Given this list of marker genes CALHM6, FCN1, RAB37, RNF144B, S100A11, MMP9, MDM1, LSM14A, TNC, HSPA1A, FSTL1, ARL15, MARVELD1, ARHGAP26, IFNLR1, TFEB, CYP27A1, ENPP4, PIGL, EPM2AIP1, GFOD2, SLC4A1, CDK5R1 (cyclin dependent kinase 5 regulatory subunit 1), FAM221A, LRRC1, TIE1, KIAA0319L, SIGLEC10 (sialic acid binding Ig like lectin 10), KLHL12, PRDX5, CFH, MS4A8, RPIA, TEDC1, RAP1GAP2, SH3BP5L, TMEM216, SSH2, PLCB4 (phospholipase C beta 4), STK39, YPEL3, S1PR4, BCAS3, GMPR, TRIOBP, KIF18A, ARHGEF18, CRYAB, UBE2L6, GYS1, FCRL1, FCSK, KHK, FANCI, LPCAT1, FN1, C1QC, H1-2, SLU7, MSANTD3, ARHGEF37, ERG, MAFB, NR4A1, SMPDL3A, ELANE, GLCCI1, MOGAT2, PPP1R15A, CHST13, TMEM176B, CHDH (choline dehydrogenase), NCAPH, MCEE, MTMR3, EFCAB11, ZBTB26, NDUFV3, CXCR2, SPIC, FOSB, FABP4, MPP7, SLC41A3, ARHGDIB, CDH11, MFSD9, ANXA2 (NCBI Gene Id 792), LRG1, LGALS4, PRODH, DTNB, SELENOM, SRSF5, NCAM1, TRIM45, PLAGL1, TTC21A, FLOT1, BACE1 (NCBI Gene Id 23621), EPAS1, AATK, HEMGN, INPP1, UBA7, MCTP2, PI16, EGR1, CD5L, TICRR, ASPRV1, CD79A, PLPP1, CLDN15, ADD3, FBXO10, HELB, PHETA2, NRM (nurim), SYNE1, MGST2, TBC1D25, FPR2, DGKG, CNMD, TRIM67, MAP3K9, NIBAN3, PPM1E, TRPM2, ABCB10, HLA-C, GHR, SELP, HP, STX11, UBC, EXOC6, OLFML3, NUP107, BBX, PLXNB2, TMCC2, ATG4C, ANKS3, SP110, OAZ1, PARP16, FOXF2, APOE, NUDT22, THBD, FCGR3A, TUBA4A, BTG1, DNAH17, PHAF1, RFC2 (NCBI Gene Id 5982), PPP1R35, ING1, SEC16B, CYRIB, PTPRC (protein tyrosine phosphatase receptor type C), NXN, BGN, DSP (desmoplakin), SYCP2L, CHI3L1, MCTP1, BBS9, HAS2, DNAH8, DGKH, SCRG1, PDE4D, TRIB1, RHOB, NCF1, SYCP2, SERPING1, VCAM1, LPCAT4, PDE2A, IGFBP4, CDK2 (NCBI Gene Id 1017), WRN, AGRN (NCBI Gene Id 389836), EIF4E3, LHFPL6, MPHOSPH9, BTG2, PLTP, KLF11, MATCAP2, CPNE2, SH2B1, PDLIM1, BTNL9, TRIP6, MAPK4, here is a description of the gene set: from publication Yamagata T, Benoist C, Mathis D (PMID 16623764) studied in species Homo sapiens Genes up-regulated in CD4 T cells versus B2 B lymphocytes. Three innate (B1-B, NKT, CD8aaT cells) and adaptive (B2-B, CD4T, CD8abT cells) cell-types were sorted by FACS. Three biological replicates for NKT, CD4T, CD8aaT, CD8abT cells and two biological replicates for B1 and B2 cells were generated and the expression profiles were determined using Affymetrix Mu74Av2 chip. Comparisons between the sample groups allow the identification of genes differentially expressed between the innate and adaptive cell-types. Human Gene Set: GSE3039_CD4_TCELL_VS_B2_BCELL_UP